The following is a description of a gene set: Human Gene Set: TBPL1_TARGET_GENES Genes containing one or more binding sites for (TBPL1) in their promoter regions (TSS -1000,+100 bp) as identified by GTRD version 20.06 ChIP-seq harmonization. from publication Yevshin I, Sharipov R, Kolmykov S, Kondrakhin Y, Kolpakov F (PMID 30445619) studied in species Homo sapiens, and this is the list of marker genes: DALRD3, POGZ, GBA1, TXNL1, MRPS6, OR4P1P (NCBI Gene Id 81056), LINC01781 (NCBI Gene Id 101927412), LRRC37A16P, ENSG00000226087, TAF6L, ATP1B3, SMARCD2, BABAM2, ENSG00000253214, NANOGP1, CCN2, SMARCD1, NHSL3, UTRN, DNAH17, NUS1P3, RNU6-1201P, LINC01100, GPC3, AKR1C4, CMKLR1, FGD4, A1CF, TERF2, LINC01980, MEGF6, LINC02402, RPL32P1, MYO1C, TCAM1P, PLOD1, TOMM40, CR2, MARCHF11-DT, OLFM4, TRPA2P, CDH9, MIR4277, PAX1, MIR1250, TRPM4, RNA5SP252, HBB, SNX8, C9orf152 (chromosome 9 open reading frame 152), TXK, TBC1D22A-DT, KRTAP19-7, SIGLEC15, RNU6ATAC3P, MLLT10, RN7SKP115 (NCBI Gene Id 106479146), LAMA4, CYCSP39, LINC01307, KIF25, AGPAT3, APOOP3, LINC02564, PXN, NRIP3, TERT, HAND2, DHRS7, LL0XNC01-250H12.3 (uncharacterized LL0XNC01-250H12.3), OMP, ARX, CCDC154, CRYM, TRBV25-1, ACOT8, GGH, DNAH11, TPTEP1, ARHGEF2-AS1, ACTMAP, KHSRP, TRIM7-AS1, HUS1, MEGF11, EEF1A1, ASXL1, GFER, WDR59, ZNF10, OTUD3, PRRT1, OR10AK1P, RPL18AP16, TRIO, ZSWIM3, ACSL3, PAXBP1, ZSCAN5C, PCNPP5, LINC01745, RECQL5, ACTBP1, MIR3147, PRPF4, YIF1B, SYTL1, RANBP1, NELFE, RPS18P14, DUS1L, MDGA1, PHB1P14, PRSS36 (NCBI Gene Id 146547), RPS26P54, MARCHF11, ATP2B4, GOLM2, FAM83B, RPPH1, RNU6-1, PABPC1, HS2ST1, MYL6P3, ATOSA, RPL26P34, ALS2, PBX2P1, MCF2L2, SQOR, SEMA6D, KLC3, SLC25A6, TAS2R9, SNRNP27, TRPM3, POLA2, PADI2, KRT36, LINC02243, RIMBP2, NOXO1, NSMAF, CCAR2, NDUFS1, BHLHE22-AS1, SNRPA, YWHABP2, IGSF9B (immunoglobulin superfamily member 9B), RSU1P2, ST8SIA3, TJP3, TGFBR1P1, ARHGEF2, CCL8, ASB15, TMEM44, AP2A2, STX6, MIR3147HG, ZGLP1, UNC13D, NAP1L4P3, TRMT2A, RNU6-509P, TBC1D22A, NR2F1-AS1, NRP1, PLCH2, MFFP1, ITFG1 (NCBI Gene Id 81533), SUCLG1, PGK1, WASH6P, RPL31P24, PPT2, TRIM25, GARS1-DT, S100A6, MTCH1, THSD4, DNM1P47, RN7SKP72 (NCBI Gene Id 106481748), HSPE1P5, SLC28A2, EPCIP-AS1, STAMBP, WDR7, UGT2A2, RPS29P20, CPSF1P2, RP2, VAT1 (NCBI Gene Id 10493), TRBC2, EEF1B2, TDRD9, LINC02684, CDHR1, RBKS, RPL41P1, CYP4B1, A4GALT, VRK3, CT62, USP24, COX17, TIMM50 (NCBI Gene Id 92609), NRXN3, TSPAN9, NAP1L1, LINC03108, SMCHD1, CYFIP1 (NCBI Gene Id 23191), RPGRIP1, HK3, OR10AA1P, KLHDC9, CSF2RA, MSANTD4, CTNNA2, PARP2, LINC01301, ESRRA, RNU6-805P, NPY1R